The following is a description of a gene set: Protein hydroxylation species: Homo sapiens Human Gene Set: REACTOME_PROTEIN_HYDROXYLATION, and this is the list of marker genes: OGFOD1, DRG1, DRG2, RPS23 (NCBI Gene Id 6228), U2AF2, RIOX1, JMJD7, RCCD1, RPS6, RPL27A, ZC3H15, RWDD1, ETF1, RIOX2, JMJD4, JMJD6, KDM8, F9, ASPH, RPL8